Given this list of marker genes Ltc4s, here is a description of the gene set: electronically inferred by orthology from the curated human pathway part of: Biosynthesis of DHA-derived SPMs Reactome Pathway: Biosynthesis of DHA-derived sulfido conjugates This event has been computationally inferred from an event that has been demonstrated in another species.<p>The inference is based on the homology mapping from PANTHER. Briefly, reactions for which all involved PhysicalEntities (in input, output and catalyst) have a mapped orthologue/paralogue (for complexes at least 75% of components must have a mapping) are inferred to the other species. species: Mus musculus